Given this list of marker genes ASB17, LEMD1, AKAP3, UBQLN3, TEX15, PGK2, CYLC2, CST9L, TSGA10, ATP6V1E2, here is a description of the gene set: from publication Weber M, Hellmann I, Stadler MB, Ramos L, Pääbo S, Rebhan M, Schübeler D (PMID 17334365) Unmethylated germline-specific genes with low-CpG-density promoters (LCP) in primary fibroblasts. To gain insight into the function of DNA methylation at cis-regulatory regions and its impact on gene expression, we measured methylation, RNA polymerase occupancy and histone modifications at 16,000 promoters in primary human somatic and germline cells. We find CpG-poor promoters hypermethylated in somatic cells, which does not preclude their activity. This methylation is present in male gametes and results in evolutionary loss of CpG dinucleotides, as measured by divergence between humans and primates. In contrast, strong CpG island promoters are mostly unmethylated, even when inactive. Weak CpG island promoters are distinct, as they are preferential targets for de novo methylation in somatic cells. Notably, most germline-specific genes are methylated in somatic cells, suggesting additional functional selection. These results show that promoter sequence and gene function are major predictors of promoter methylation states. Moreover, we observe that inactive unmethylated CpG island promoters show elevated levels of dimethylation of Lys4 of histone H3, suggesting that this chromatin mark may protect DNA from methylation. Human Gene Set: WEBER_METHYLATED_LCP_IN_FIBROBLAST_DN species: Homo sapiens